The following is a description of a gene set: Human Gene Set: GOBP_TYPE_II_PNEUMOCYTE_DIFFERENTIATION studied in species Homo sapiens The process in which a relatively unspecialized cell acquires specialized features of a type II pneumocyte. A type II pneumocyte is a surfactant secreting cell that contains abundant cytoplasm containing numerous lipid-rich multilamellar bodies., and this is the list of marker genes: GATA6, AIMP2, FGF10, RBBP9, IGF1 (NCBI Gene Id 3479), NFIB, NKX2-1